Given this list of marker genes GNB4, GNA15, GNG12, POMC, GNG3, OPRM1, PDYN, GNA11, GNB1, GNG11, GNGT2, GNG8, GNG5, GNB3, GNG13, GNA14, GNG7, GNB2, GNG4, GNG10, GNB5, GNG2, GNAQ, GNGT1, here is a description of the gene set: species: Homo sapiens Human Gene Set: REACTOME_G_PROTEIN_ACTIVATION G-protein activation